Given this list of marker genes EHD3, TMED5, RAB43, SEC16A, RAB2A, GOLGA8M, CLASP1, ATP8B1, SPTBN5, USP6NL, GOLGA8IP, YIPF7, PLK3, TMED4, RAB30, ARMH3, ATP8B3, GOLGA8O, RAB1B, CSNK1D, FAM174B, ARHGAP21, ARHGEF7, PTK2B, TRAPPC12, AKAP9, RAB33B, GCC2 (NCBI Gene Id 9648), PRMT5, NAGLU, UBXN2B, COG3, COG1, HIKESHI, CORO7, STX5, COG4, GOLGA8CP, GOLGA8B, ATP8B4, GOLGA6C, SYNE1, OPTN, GOLGA8Q, GOLPH3L, COG7, GORASP2, VPS51, TMED1, VRK1, CUL7, ARL1, CLASP2, HACE1, VTI1B, PI4K2B, MAP2K2, GOLGB1, CAMSAP2, NSFL1C, ATP8B2, GOLPH3, PI4K2A, TANGO2, STX17, GOLGA8A, RAB29, GOLGA6B, CDC42, HUWE1, ZW10, UBXN2A, TJAP1, MYO18A, BHLHA15, GORASP1, KIFC3, MAP2K1, GOLGA8H, VTI1A, AP5Z1, GARIN4, GOLGA8N, TRAPPC11, GOLGA8R, GAK, CAMSAP3, NPLOC4, HOOK1, RBSN, PLK1, TMED2, CDK1, VPS13B, COG5, YWHAZ, VCPIP1, STX18, TMED6, PDCD10, MYO5A, MAPK3, SEC16B, RAB2B, RAB1A, TMED7, TBC1D20 (TBC1 domain family member 20), GOLGA8T, RAB8A, LMAN1, GOLGA8DP, PDE4DIP, ARFGEF1, DYM, MAPK1, CRYZL2P-SEC16B, FHDC1, GOLGA6A, SEC23IP, CSNK1A1, BET1, LRRK2 (NCBI Gene Id 399472), TMED9, GOLGA5, PLEKHM2, DYNC2H1, OBSL1, VAMP4, ZFP69B, COG8, GOLGA8J, SURF4, VMP1, FBXW8, COG2, RAB6B, YIPF5, YIPF4, STK25, GOLGA8K, PRKD1, LYSMD3, GBF1, GOLGA8S (NCBI Gene Id 653061), ZNF501, TMED3, USO1, GOLGA6D, BAG5, TRAPPC8, COG6, TMED10, HTT, TRIP11, GOLGA2, BLZF1, here is a description of the gene set: A process that is carried out at the cellular level which results in the assembly, arrangement of constituent parts, or disassembly of the Golgi apparatus. Human Gene Set: GOBP_GOLGI_ORGANIZATION species: Homo sapiens